Given this list of marker genes Foxc1, Egln1, Zfpm1, Nrg1, Klk1b1, Tnni3, Smad4, Myl2, Rxra, Foxc2, Sirt6, Eng, Nog, Prox1, Hey2, Pkp2, Wnt2, Naglu, Tnni1, Tnnc1, Ryr2, Smad7, Heg1, Col11a1 (NCBI Gene Id 77655), Tbx20, Myh6, Pitx2, Lrp6, Zfpm2, Med1, Fkbp1a, Xirp2, Ttn, Dll4, Notch1, Hey1, Tnnt2, Lrp2, Rbpj, Ptcd2, Tcap, Bmp2, Angpt1, Ly6e, S1pr1, Tgfb1, Myl3, Ednra, Ctnnb1, Mybpc3, Bmp10, Foxh1, Fgfr2, Nkx2-5, Ccm2l, Tgfbr3, Dsp, Tgfbr1, Epo, Epor, Ankrd1, Actc1, Bmpr1a, Tgfb2, Pou4f1, Chd7, Hand1, Myh7, Ube4b, Mylk2, Tpm1 (tropomyosin 1, alpha), Isl1, here is a description of the gene set: species: Mus musculus Mouse Gene Set: GOBP_CARDIAC_MUSCLE_TISSUE_MORPHOGENESIS The process in which the anatomical structures of cardiac muscle tissue are generated and organized.